Given this list of marker genes CERK, MAPKAPK2, GPLD1, CYP4V2, NCMAP (NCBI Gene Id 400746), TMEM170B, TMBIM1, ELF1, TJP2, OPA3, AREG, ZFP36 (ZFP36 ring finger protein), RPS19BP1, CNKSR3, CHMP4C, HERPUD1, TPD52, NEB, PRDM1 (PR/SET domain 1), IFNGR1, TM7SF3, GALC, PLD3, TMTC2, HOPX, SESN1, PCYT1A (phosphate cytidylyltransferase 1A, choline), BCL3, CDKN1A, GPANK1, DYNLT1, CRLF2, ATXN7L1, ELOVL6, GEM, SYTL2 (NCBI Gene Id 84564), CSGALNACT1, PPM1B, SORBS1, PCSK1, TGIF2, TULP4, MLXIP, MLF1, LAPTM4B, PIEZO1, PPM1L, ZNF503, IRF5, MYOG, SQSTM1, GLS2, LZTFL1, SLC29A1, TSPAN31, COBLL1, DMXL2 (Dmx like 2), KLRG1, KCNA4, SWAP70, SLC66A2, BACE2, GALNT1, FASTKD3, ACSF3, SLC52A3, OSBPL3, ATF3, NCKAP1, LRRC8C, SMIM3, GM2A, DBNDD2, TNFRSF18, ZCCHC24, PLP2 (proteolipid protein 2), NEU3, NAV2, ARL14EP, ARMCX1, RELB, PRICKLE3, CSRP2, ABLIM3, ATP8A1, IL18, RGS16, GPX1, FAM98B, PPARG, DHX40, C1QTNF12, KDSR, PLCL1, PDCD1, SLC37A2, DUSP4, SERPINB6, CXCL10 (NCBI Gene Id 3627), ALOX15B, SYNGR2, ZFP36L1, PCK2, FXYD5, FEM1C, SNX9, NADK, PSMB2, CASS4, ERMP1, LTB4R, JDP2, MTMR10, FGL2, EBI3, CAP2, DUSP1, TGIF1, PRKAB2, NFKBIZ, SLC35B2, NPNT, ZC2HC1A, DNAJB12, TBC1D19, SLC39A1, EIF4A1 (NCBI Gene Id 1973), MITF (NCBI Gene Id 7487), PAX6, IL10RA, CYFIP1, ARRB1, SAMSN1, HMGCS1, ARL6, CD200R1, NDRG1, CMTM7, PLXDC1, MIF4GD, EHD4, ARHGAP6, ADGRG3, PTGES3, STX11, MAP4K5, ENPP4, PLEKHA7, SPTY2D1, TNFAIP8L1, APH1B, ITGB3, ANXA1, ZC3H12A, DOT1L, PLCB4, ELOVL5, DYNLT3, HPGD, MID1IP1, ATP13A3, RABGEF1, ISG20, ARL5B, COQ8A, TSPAN13, ARNT2, VPS45, PLIN2, YPEL2, BPNT1, PHLDA1, FRMD5, DNAJB13, PROS1, ZC3HAV1, MAGI1 (NCBI Gene Id 9223), RAB4A, RAB7A, LCLAT1, NFKBIE, IL1R2, PLXND1, GLRX (NCBI Gene Id 90885), SLC25A19, HS6ST2, CPM, ARHGAP31, M6PR, PLEC, ALCAM, GNAQ, TNFRSF9 (NCBI Gene Id 3604), JCAD, KIFAP3, SH3PXD2A, ITGAV, ASL, SNX3, ITPRIPL2, here is a description of the gene set: species: Homo sapiens Comparisons of global gene-expression profiles revealed a greater distinction between CD4+ Treg cells and CD4+ conventional (Tconv) T cells residing in abdominal (epidydimal) fat versus in more standard locations such as the spleen, thymus and LN. from publication Feuerer M, Herrero L, Cipolletta D, Naaz A, Wong J, Nayer A, Lee J, Goldfine AB, Benoist C, Shoelson S, Mathis D (PMID 19633656) Human Gene Set: GSE7852_TREG_VS_TCONV_FAT_UP Genes up-regulated in comparison of fat tissue regulatory T cells versus fat tissue conventional T cells.